The following is a description of a gene set: An abnormal reduction in the mobility of ejaculated sperm. Human Gene Set: HP_REDUCED_SPERM_MOTILITY Reduced sperm motility studied in species Homo sapiens, and this is the list of marker genes: CEP112, LRRC23, DNAH17, GAS2L2, CFAP251, CCDC146, TTC29, CCDC40, ALG9, CFAP410, DNHD1 (dynein heavy chain domain 1), AK7, SPEF2, RSPH4A, DNAH2, CATIP, HYDIN, BRDT, CATSPER2, DNAH10, KCNU1, ZMYND10, CFAP65, PKD1, CFAP47, STK36, CT55, BRWD1, DNAH1, CATSPER1, PMFBP1, CFAP70, PKD2, ARMC2, DZIP1 (NCBI Gene Id 22873), CFAP69, SUN5 (Sad1 and UNC84 domain containing 5), GBA2, TTC21A, IFT140, DNAAF5, CFAP43, KLHL10, CFAP91 (cilia and flagella associated protein 91), PDHA2, FSIP2, STRC, CFAP58, DNAJB11, IFT74, SSX1, CCIN, DNAH7, CCDC39, SPINK2, USP26, CCDC34, CFAP61, BICC1, STK33, SEPTIN12, CFAP298 (cilia and flagella associated protein 298), DNAH8, CDC14A, SLC26A8, HNF1B, ARL2BP, GANAB, RSPH9, DNALI1, SPAG17, ALG5, DNAJB13